Given this list of marker genes NTRK1, FCRL4, MLLT11, ABL2, MUC1, HSP90AA1, FCGR2B, PRCC, ARNT, PBX1, TPR, FH, TPM3, SDHC, BCL9, PAX7, CDC73, TSC22D3, PRRX1, here is a description of the gene set: from publication Myllykangas S, Himberg J, Böhling T, Nagy B, Hollmén J, Knuutila S (PMID 16751803) studied in species Homo sapiens Amplification hot spot 17: colocalized fragile sites and cancer genes in the 1q11-q44 region. DNA copy number amplifications activate oncogenes and are hallmarks of nearly all advanced tumors. Amplified genes represent attractive targets for therapy, diagnostics and prognostics. To investigate DNA amplifications in different neoplasms, we performed a bibliomics survey using 838 published chromosomal comparative genomic hybridization studies and collected amplification data at chromosome band resolution from more than 4500 cases. Amplification profiles were determined for 73 distinct neoplasms. Neoplasms were clustered according to the amplification profiles, and frequently amplified chromosomal loci (amplification hot spots) were identified using computational modeling. To investigate the site specificity and mechanisms of gene amplifications, colocalization of amplification hot spots, cancer genes, fragile sites, virus integration sites and gene size cohorts were tested in a statistical framework. Amplification-based clustering demonstrated that cancers with similar etiology, cell-of-origin or topographical location have a tendency to obtain convergent amplification profiles. The identified amplification hot spots were colocalized with the known fragile sites, cancer genes and virus integration sites, but global statistical significance could not be ascertained. Large genes were significantly overrepresented on the fragile sites and the reported amplification hot spots. These findings indicate that amplifications are selected in the cancer tissue environment according to the qualitative traits and localization of cancer genes. Human Gene Set: MYLLYKANGAS_AMPLIFICATION_HOT_SPOT_17